Given this list of marker genes Slc66a1, Slc36a4, Slc15a4, Slc38a3, Slc6a14, Slc36a1, Slc38a5, Slc7a1, Slc16a10, Slc3a2, Slc43a2, Slc36a2, Slc7a5, here is a description of the gene set: Enables the transfer of aromatic amino acids from one side of a membrane to the other. Aromatic amino acids have an aromatic ring. species: Mus musculus Mouse Gene Set: GOMF_AROMATIC_AMINO_ACID_TRANSMEMBRANE_TRANSPORTER_ACTIVITY